Given this list of marker genes GPIHBP1, APOH, ANGPTL4, LPL, ANGPTL3, APOA4 (apolipoprotein A4), APOC2, here is a description of the gene set: Human Gene Set: GOBP_CHYLOMICRON_REMODELING studied in species Homo sapiens The acquisition, loss or modification of a protein or lipid within a chylomicron, including the hydrolysis of triglyceride by lipoprotein lipase and the subsequent loss of free fatty acid.